Given this list of marker genes HPS6, PHF13, SOCS5, GOLGA1, NCOA3, MIR99AHG, CBX2, RPL22L1, RPL27A, LEF1, SOS1 (NCBI Gene Id 7838), MRPL41, GID4 (GID complex subunit 4 homolog), ZMYM5, S1PR1, XRCC2, LPCAT1, TASOR, NHERF1, COPS5, ARHGAP30, UGCG, C8orf76, HARBI1, SULF2, DNAAF2, DEPTOR, WASF2, PRR9 (proline rich 9), S1PR2, TCERG1, HPDL (NCBI Gene Id 84842), CSRNP2, OARD1, CYB561A3, NHSL3, SH3BP2, MRPL22, GNPDA1, ESF1, ABHD14B, TMEM238L, CHD1, TRIM8, MID1IP1, CCDC80, S100A1, ACSL3, TMEM86A, GSE1, AMZ1, PSEN2, GAST, THBS1, RCBTB1, ZNF697, PPP1R18, B4GALT1, ZNF546, SASH3, KIF21B, SELENOP, CCDC39, SPINK4, MPP1, C12orf57, DNAJB14, RASA2, PGP (phosphoglycolate phosphatase), POLK, CEP19, TOGARAM1, FBLIM1, MOB3A, USP49, HPSE, KCTD11, RAB22A, KMT2A, TOB1, CERT1, C1orf35, KMT2E, COL13A1, YTHDF2, MYH9, ENC1, ACBD3, TNFRSF1A, DNAJC7, ZFP30, PRKRA, IFT27, SLITRK5, HAUS3, TRIO, MTFR1L, RNF168, HABP4, USP32, CCNL2, KLHL15, FERMT2, EOLA1 (endothelium and lymphocyte associated ASCH domain 1), HEY2, NEK7, AMMECR1L, TMOD1, LENG8, PDXP, LONRF3, RBM38, CUL9, EDIL3, TRAPPC8, FUT1, FOXO3, BOLA2, GYG1, EPAS1, MTERF1, LYL1, CTSD, PAN3, BTBD19, ZNF512B, CNOT4, ALDH1L2, WWTR1, CREBBP, SUN2, DYNLL2, DHRS3, PPM1D, FBXW4, HLTF, SLC12A6, RAC1, ARHGAP32, SYNPO2, ANKRD1, RDH14, SETD1B (NCBI Gene Id 23067), TMEFF1, SLC49A4, NCBP2, FASTKD5, EIF5A2, UBXN2B, C11orf54, PCYT1A, ZNF524, ANKRD52, PDIK1L, ZNF358, SLC15A4, SMIM15 (NCBI Gene Id 649861), RNF180, PLPP5, KIF3A, KBTBD4, LGALS1, SVIP, ZFC3H1, KLHL20, SYTL4, RETREG3, ALG14, DDI2, FABP5, SERPINB6, CSNK1E, ENTPD2, FHL1, CAMKK1, SNX9, IL11RA (NCBI Gene Id 3590), FAM78A, AAGAB, SELENOM, TMEM126A, YAE1, KLHL30, DCAF10, TMTC3, TIMM9 (NCBI Gene Id 26520), QTRT2, IFFO1, CHD3, AKR7A2, TM6SF1, BAZ1A, PRICKLE1, KPNA4, RNF6, EYA4, CCNC, FLCN, SLC36A4, BCORL1, here is a description of the gene set: from publication Koziczak-Holbro M, Glück A, Tschopp C, Mathison JC, Gram H (PMID 18266302) Genes up-regulated in comparison of untreated macrophages at 4 h versus those treated with LPS (TLR4 agonist) at 1 h. studied in species Homo sapiens Human Gene Set: GSE9037_CTRL_VS_LPS_1H_STIM_BMDM_UP IRAK-4 is an essential component of the signal transduction complex downstream of the IL-1- and Toll-like receptors. Though regarded as the first kinase in the signaling cascade, the role of IRAK-4 kinase activity versus its scaffold function is still controversial. In order to investigate the role of IRAK-4 kinase function in vivo, ‘knock-in’ mice were generated by replacing the wild type IRAK-4 gene with a mutant gene encoding kinase deficient IRAK-4 protein (IRAK-4 KD). Analysis of bone marrow macrophages obtained from WT and IRAK-4 KD mice with a number of experimental techniques demonstrated that the IRAK-4 KD cells greatly lack responsiveness to stimulation with the Toll-like receptor 4 (TLR4) agonist LPS. One of the techniques used, microarray analysis, identified IRAK-4 kinase-dependent LPS response genes and revealed that the induction of LPS-responsive mRNAs was largely ablated in IRAK-4 KD cells. In summary, our results suggest that IRAK-4 kinase activity plays a critical role in TLR4-mediated induction of inflammatory responses.